Given this list of marker genes Ccl5, Cxcl9, Cxcl10, Ccr8, Cxcr3, Ccl21a, Ccr4, Cxcl2, Cxcr6, Ccl21f, Ccr7, Ccr10, Pf4, Cxcl12, Cxcr2, Cxcl3, Ackr2 (NCBI Gene Id 59289), Ccl19, Ackr4, Ccl3, Cxcr5, Ccr6, Ccl11, Cxcr4, Ccl17, Ccl4, Ccl7, Ccl21e, Ccl20, Ccl28, Cx3cr1, Cxcl16, Ccl12, Ccr3, Cxcr1, Xcr1, Cxcl1 (NCBI Gene Id 14825), here is a description of the gene set: This event has been computationally inferred from an event that has been demonstrated in another species.<p>The inference is based on the homology mapping from PANTHER. Briefly, reactions for which all involved PhysicalEntities (in input, output and catalyst) have a mapped orthologue/paralogue (for complexes at least 75% of components must have a mapping) are inferred to the other species. Reactome Pathway: Chemokine receptors bind chemokines species: Mus musculus electronically inferred by orthology from the curated human pathway part of: Peptide ligand-binding receptors